The following is a description of a gene set: Mouse Gene Set: GOBP_REGULATION_OF_MRNA_PROCESSING Any process that modulates the frequency, rate or extent of mRNA processing, those processes involved in the conversion of a primary mRNA transcript into a mature mRNA prior to its translation into polypeptide. studied in species Mus musculus, and this is the list of marker genes: Upf3a, Gm7324, Rbmyf6, Qki, Thumpd2, Srsf9, Rest, Rbfox2 (RNA binding protein, fox-1 homolog (C. elegans) 2), Khdrbs2, Arglu1, Ncbp1, Pcbp4, Larp7, Srsf10, Zbtb7a (NCBI Gene Id 71606), Eif4a3, Myod1, Hnrnpk, Magohb, Celf3 (NCBI Gene Id 78784), Fmr1, Mbnl1, Sap18, Jmjd6 (NCBI Gene Id 70547), Zfp64, Ptcd2, Hnrnpa2b1, Npm1 (NCBI Gene Id 18148), Rbmyf3, Safb2, Upf3b, Prdx6b, Rbm25, Nsrp1, Srrm4, Fip1l1, Cdc73, Srsf7, Srsf6 (serine and arginine-rich splicing factor 6), Larp7-ps (NCBI Gene Id 68280), Nova2, Arb2a, Rbm7 (RNA binding motif protein 7), Smu1, Rbmyf9 (NCBI Gene Id 100041505), Adam3, Dhx9, Pabpn1, Tra2b, Rbm42, Rbm47, Sltm, Clns1a, Srsf12, Srsf3, Srpk1, Srsf8, Mbnl2, Rbm39 (RNA binding motif protein 39), Srpk3, Magoh, Zfp36l1, Tra2a, Rbmxl1, Celf6, Dazap1, Tia1, Nup98, Ddx5, Rbmx (NCBI Gene Id 19655), Ncl, Rbmyf1, Rbm3 (RNA binding motif (RNP1, RRM) protein 3), Eif1 (NCBI Gene Id 217191), Ptbp1, Rbm20, Upf1, Rbm24, Wtap, Mettl16, Rbm4, Pabpc2, Hspa8, Celf4, Prpf19, Rbm15b, Sap18b, Khdrbs3, C1qbp (NCBI Gene Id 28127), U2af2, Ddx17, Hnrnpl, Srsf4, Acin1, Rbfox1, Ythdc1, Cirbp, Dhx36, Rnps1, Rbpms, Exosc10 (NCBI Gene Id 50912), Thrap3, Akr1c6, Hmx2, Safb, Cdk9, Alkbh5, Adarb1, Snw1, Obi1, Sf1, Prmt5, Lmntd2, Srpk2, Cpeb1, Rbfox3, Dyrk1a, Iws1, Rbm10, Srrm1, Kat8, Rbm11, Hnrnpu, Celf2, Sfswap (splicing factor SWAP), Prdx6, Supt6, Rbmy, Nova1, Puf60, Slc39a5, Celf1, Ccnb1, Son, Rbm15, Srsf2, Ptbp3, Hdac7, Khdrbs1, Rbmxl2, Snrnp70, Wdr77, Rbm8a, Celf5, Slirp, Rbm5, Rbm8a2, Rbpms2, Malat1, Ahcyl1